The following is a description of a gene set: from publication Yosef N, Shalek AK, Gaublomme JT, Jin H, Lee Y, Awasthi A, Wu C, Karwacz K, Xiao S, Jorgolli M, Gennert D, Satija R, Shakya A, Lu DY, Trombetta JJ, Pillai MR, Ratcliffe PJ, Coleman ML, Bix M, Tantin D, Park H, Kuchroo VK, Regev A (PMID 23467089) Human Gene Set: GSE43955_1H_VS_60H_ACT_CD4_TCELL_UP Despite their enormous importance, the molecular circuits that control the differentiation of Th17 cells remain largely unknown. Recent studies have reconstructed regulatory networks in mammalian cells, but have focused on short-term responses and relied on perturbation approaches that cannot be applied to primary T cells. Here, we develop a systematic strategy – combining transcriptional profiling at high temporal resolution, novel computational algorithms, and innovative nanowire-based tools for performing gene perturbations in primary T cells – to derive and experimentally validate a temporal model of the dynamic regulatory network that controls Th17 differentiation. The network is arranged into two self-reinforcing and mutually antagonistic modules that either suppress or promote Th17 differentiation. The two modules contain 12 novel regulators with no previous implication in Th17 differentiation, which may be essential to maintain the appropriate balance of Th17 and other CD4+ T cell subsets. Overall, our study identifies and validates 39 regulatory factors that are embedded within a comprehensive temporal network and identifies novel drug targets and organizational principles for the differentiation of Th17 cells. Genes up-regulated in CD4 T helper cells Th0: 1h versus 60h. studied in species Homo sapiens, and this is the list of marker genes: TRAPPC3, USP18, HSPA1A, TRIO, SAYSD1, NNMT, TEAD1, HIPK3, SLC25A51, DEGS1, PHLDA1, TYSND1, LGALS3BP, SLC38A10, ALAS1, RER1, CCN1, TUBB6, TOR1AIP2, GLA, RANBP1, BUB1, PSMB5, NGDN, LCP1, LAT2, BCL2A1, TXNRD1, PCNT, ADAM8, GDF3, RETSAT, CHRNG, NUTF2, ANGPT1, IGF1, GSN, NDUFS3, GABARAPL2, SEC11A, CD48, AGFG1, COX17, FYTTD1, CDKN2B, GIPC1, TAPBP, HCCS, RBM22, H3C7, IFIT3, VPS37C, RAB24, LY86, SELPLG, EPRS1, DYNC1I2, COMMD5, CYTH1, GPCPD1, SMAD3, PRDX5, GADD45A, GUF1, ADORA2B, FCF1, CISD1, NUDCD2, TPMT, C1QA, SYT10, RSPO1 (NCBI Gene Id 284654), RTN4, PLTP, MAP7D1, EIF3D, ADPRH, PCBD2, CRIP1, ARHGEF25, HLA-DQA1, MAP3K11, ZFR, IKBKE, MDFIC, LATS2, CYFIP1, EIF1AX, CD72, IL10, PCSK7, CARD19, ITGA5, ZNF467, PAM, NXF1, PADI3, CSF2, PSMB4, UBE2K, ZFAND5, BGN, RABGGTA, CSNK1A1, RTF2, ALCAM, AP3S2, KCNN4, RAC3, RRP12, VRK1, TUBB2A, ELF4, ADAM17, COL5A2, PPDPF, OMP, PLAUR, PLK4, CD300C, SLC39A6, MAPRE1, MRPS25, RGS16, FYN, TRAF1, SATB1, NDUFA8, OGA, DNAAF10, NAB1 (NGFI-A binding protein 1), RPA2, GK, MLH1, DUSP1, IL18R1, CHCHD3, AKR1E2, IL1RN, TMEM176A, SWI5, FEM1B, PMP22, SNAI1, CMTM3, CPEB2, FOLR2, ACKR2, DBNDD2, RORC, GREM1 (gremlin 1, DAN family BMP antagonist), C1QB (complement C1q B chain), PDGFB, STRN4, AGAP3 (ArfGAP with GTPase domain, ankyrin repeat and PH domain 3), PEX19, ALDH9A1 (aldehyde dehydrogenase 9 family member A1), TFIP11, CD5L, TRAPPC2L, ADCY4, RCAN1, CDKN1C, NAB2, TRPV2, ENTPD7, HNF1A (HNF1 homeobox A), NDUFA9, PTGER4, CERS2, SMNDC1, MRPS18B, ASIP, ATOX1, SNRPA, RNH1, KCNA3, AK1, LY9, CD52, ARPC1A, C5orf15, DYNLL2, INO80C, AREG (NCBI Gene Id 727738), DOK1, CLIC4, SDHC, NDUFA2 (NADH:ubiquinone oxidoreductase subunit A2), FCGR1A, MTCH2, FXYD5 (FXYD domain containing ion transport regulator 5), SIPA1L2, BRK1, CCR5, MRPS26, SNRPD3, NOCT, DKK3, CNN3